Given this list of marker genes Elavl2, Ptpru, Mgat4a, Zbtb34, Dip2c, Schip1, Tmem230, Adcyap1r1, Fam222b, Usp49, Pdhx, Dzip3, Pip4k2a, Aebp2, Tgif1, Rreb1, Avl9, Rab27a, Ube2e3, Slc5a3, Tbx1, Cnih1, Ap1s2, Akirin2, Fbn2, Cacna2d1, Ankrd63 (ankyrin repeat domain 63), Kmt5b, Zfp763, Nt5m, Arf6, Pigm, Zfp120, Atp2b2, Adcy1, Zfp1005, Pramel3c, Rock1, Elovl5, Tmpo, Cds1, Pmp22, Psma8, Fos, Pramel3b, Fzd3, Jun, Slc33a1, Osbpl8, Cwc25, Atrx, Pde4d, Sema6d, Adgra1, Tspan5 (NCBI Gene Id 99819), Zfyve27, Hipk1, Coq3, 2410004B18Rik, Ube2f, Fam76b, Pramel3a, Tet3, Golm2, Flt3, Zeb2, Ndrg4, Zfp619, Arx, Dmd, Rem1, Usf3, Nectin3, Pja1, Ofd1, Cdk6, Zeb1, Lrfn5, Txlng, Pcdh7, Tmtc3, Gdf10, Nptx1, Prpf4, Slc23a2, Rfx7, Atosa, Kbtbd2, Eif5a2, Iigp1, Trpc7, Eif4e3, Tmem200c, Prdm16, Taok1, Prpf4b, Usp14, She, Pde4a, Pik3r3, Fmr1, Lrp2, Pfkfb2, Dpy30, Tmem33, Meis2, Pde3a (phosphodiesterase 3A, cGMP inhibited), Baz2b, Bche, Birc6, Eif4g2, Nrk, Zfp874a, Mycbp, Pramel3e, Taf7l2, Cdh20, Atad1, Zfp616, F2r, Ints10, Traf3, Zfp846, Iqschfp, Ubr3, Ebf1, 6030498E09Rik, Kat6a, Hoxd10, Ash1l, Morn4, Pi4k2a, Slc25a3, Zranb2, Zfp148, Hnrnpll, Bcl2, Atl2 (atlastin GTPase 2), Zfp748, Gclc, Cxcr4, Pcdh10, Psph, Scaper, Ssx2ip, Irak1bp1, here is a description of the gene set: from publication Chen Y, Wang X (PMID 31504780) Mouse Gene Set: MIR_139_5P species: Mus musculus Genes predicted to be targets of miRBase v22 microRNA mmu_miR_139_5p in miRDB v6.0 with MirTarget v4 prediction scores > 80 (high confidence targets).